The following is a description of a gene set: An abnormality of the dorsal columns, i.e., of the dorsal portion of the gray substance of the spinal cord. The dorsal column consists of the fasciculus gracilis and fasciculus cuneatus and itself is part of the dorsal funiculus. studied in species Homo sapiens Human Gene Set: HP_ABNORMALITY_OF_THE_DORSAL_COLUMN_OF_THE_SPINAL_CORD Abnormality of the dorsal column of the spinal cord, and this is the list of marker genes: ATXN1, ABCD1, SETX, DARS2, ALDH18A1